Given this list of marker genes TPP1, XRCC1, ITPR1, GDAP2, ATXN1, KCNN2, GRM1, ANO10, TMEM240, PRDX3, VPS41, VPS13D, here is a description of the gene set: Human Gene Set: HP_HYPERMETRIC_SACCADES A saccade that overshoots the target with the dynamic saccade. Hypermetric saccades studied in species Homo sapiens